Given this list of marker genes TLR5, LHFPL6, COMTD1, MYC, MUC20, RND3, CAPNS2, CCL2, SIX1, SPDEF, ZNF385B (NCBI Gene Id 151126, zinc finger protein 385B), DUSP10, PAQR4 (NCBI Gene Id 124222), SOD3, STEAP4, MUC5B, NR4A2, CDH2, ANXA1, ARHGEF38, CXCL8, SPINK1, MUC15, VCAN, TSPAN1, SLC44A4, WIPI1, KLK11, BRINP2, BHLHE40, CRIM1, ARSJ, CHST9, KRT15, CNTN1, CFH, CRYM, JAKMIP2, NIBAN1, S100P, PAPSS2, CXCL1, PRSS12, ADRA2A, NEBL, FOXO1, PFKP, EPB41L4A, KLK10, TRIM14, PAX9, ATP2A3, S100A2, KCNE5, IFITM1, PAG1, OSR1, RUNX1, CP, CYBRD1, TNFSF10, PLAT, DPYSL3, BMPR1B, WDR49, HCAR2, DRAIC, CAPS, GK, FNBP1, LIPH, PCDH7, HS3ST1, COL6A2, TMEM150C, GLIPR2, DGKH, PWWP3B, AGR3, CEACAM6, TLL1, ASAP1, ITGA1, MEG3, ELAPOR1, SCUBE3, ARFGEF3, CXCL2, MAFB, LINC01503, KDR, DUSP4, EMP1, TMPRSS4, SCGB3A1, SPINK5, ISL1, FMO2, ISG20, LNX1, GRHL1, ST6GALNAC1, TMEM40, LYPD6B (NCBI Gene Id 130576), STING1, ITIH2, BCL6, MLPH, ABCA7, SULT2B1, GLIS3, NDUFA4L2, EHF, PLPP2, TIMP1, SERPINA1, SLPI (NCBI Gene Id 6590), MEIS1, ITGB4 (integrin subunit beta 4), HPGD, SAMHD1, LMO3, RHOV, NXPH4, NPNT, LMTK3, MAGI2, CYTL1, NTN1, CAMK1D, COL16A1, SLITRK6, CDKN1A, PROM1 (prominin 1), CCNO, here is a description of the gene set: Human Gene Set: HE_LIM_SUN_FETAL_LUNG_C1_PROXIMAL_SECRETORY_PROGENITORS_CELL Proximal secretory progenitors species: Homo sapiens from publication He P, Lim K, Sun D, Pett JP, Jeng Q, Polanski K, Dong Z, Bolt L, Richardson L, Mamanova L, Dabrowska M, Wilbrey-Clark A, Madissoon E, Tuong ZK, Dann E, Suo C, Goh I, Yoshida M, Nikolić MZ, Janes SM, He X, Barker RA, Teichmann SA, Marioni JC, Meyer KB, Rawlins EL (PMID 36493756)